The following is a description of a gene set: The aggregation, arrangement and bonding together of a set of components to form an U2-type prespliceosome. species: Homo sapiens Human Gene Set: GOBP_U2_TYPE_PRESPLICEOSOME_ASSEMBLY, and this is the list of marker genes: SF3A3, SF3A1, SNIP1, SF3B2, SNRPD3, SNRPD1, SNRPE, HTATSF1, SNRPD2, SF3B1, SNRPA1, SF3B3, SNRPB2, SF3A2, RBMX2, SF3B5, DDX46, SF3B4, SNRPG (small nuclear ribonucleoprotein polypeptide G), PHF5A, DDX42, SF3B6, BUD13 (BUD13 homolog), SNRPB, SNRPF